Given this list of marker genes Pcid2, Ddrgk1, Il2rg, Spi1 (Spi-1 proto-oncogene), Bad, Atp11c, Inpp5d, Stat5a, Mmp14, Syk, Stat5b, Nckap1l, Il7, Il2, Il10, Il21, Cd27, Pnp, Ppp2r3c, Xbp1, here is a description of the gene set: Mouse Gene Set: GOBP_POSITIVE_REGULATION_OF_B_CELL_DIFFERENTIATION Any process that activates or increases the frequency, rate or extent of B cell differentiation. studied in species Mus musculus